Given this list of marker genes LIG1, POLD1, POLA2, FEN1, DNA2, PCNA, RFC4, RFC2, POLD4, PRIM1, RPA2, PRIM2, POLD2, POLA1, RFC3, RFC1, POLD3, RPA3, RFC5, RPA1, here is a description of the gene set: species: Homo sapiens Due to the antiparallel nature of DNA, DNA polymerization is unidirectional, and one strand is synthesized discontinuously. This strand is called the lagging strand. Although the polymerase switching on the lagging strand is very similar to that on the leading strand, the processive synthesis on the two strands proceeds quite differently. Short DNA fragments, about 100 bases long, called Okazaki fragments are synthesized on the RNA-DNA primers first. Strand-displacement synthesis occurs, whereby the primer-containing 5'-terminus of the adjacent Okazaki fragment is folded into a single-stranded flap structure. This flap structure is removed by endonucleases, and the adjacent Okazaki fragments are joined by DNA ligase. part of: DNA strand elongation Reactome Pathway: Lagging Strand Synthesis